Given this list of marker genes KMO, KYAT1, ALDH8A1, KYNU, KYAT3, here is a description of the gene set: studied in species Homo sapiens Human Gene Set: GOBP_L_KYNURENINE_METABOLIC_PROCESS The chemical reactions and pathways involving L-kynurenine, the L-enantiomer of the amino acid kynurenine (3-(2-aminobenzoyl)-alanine).